The following is a description of a gene set: Genes predicted to be targets of miRBase v22 microRNA mmu_miR_7020_5p in miRDB v6.0 with MirTarget v4 prediction scores > 80 (high confidence targets). species: Mus musculus from publication Chen Y, Wang X (PMID 31504780) Mouse Gene Set: MIR_7020_5P, and this is the list of marker genes: Vat1l, Mtcl2, Mllt6, Mrpl45, Col5a2, Kirrel1, Map3k8, Syn1, Cebpa, Ftcd, Cpsf6, Mtss2, Ttc39b, Klf12, Atf7, Lingo3, Hoxc8, Ptpru, Cnot9, Psg25, Shisa3, Slc39a5, Tex2, Ubxn2a, Gapdh, Taf3, Exo5, Aifm1, Ubap2l, Clec3a, Stc1, A1cf, Col6a2, Ager, Sh2d2a, Inca1, Rbm42, Trpc4ap, Hic2, Nbea, Nkx2-5, Gria1, Pip5k1c, Gm11437, Cgn, Ncoa4, Pou2f3 (POU domain, class 2, transcription factor 3), Gsdmc4 (NCBI Gene Id 74548), Nav2, Aldoart2, Adam19, Rph3al, Bysl, Bsdc1, Rnf157, Ppp1r7, Csnk1g3, Axl, Zfp873, Cep128, Ivl, Zer1, Srprb, Dennd4b, Pias1, Slc8a1, Daam2, Snap29, Cacnb1, Crim1, Dab1, Iqsec2, Rnf222, Rnf44, Sprn, Crppa, Peak1, Hnf1b, Nav1, Agtpbp1, Fchsd2, Pex19, Sulf2, Snph (syntaphilin), Ppp1r26, Mast3, Cplx2, Tmem92, Tspoap1, Fam168b, Rnf24 (NCBI Gene Id 98914), Csmd2, Celf5, Tnfsf12, Pym1, Dnm1, Ankrd12